The following is a description of a gene set: Human Gene Set: GOBP_GRANULOCYTE_DIFFERENTIATION species: Homo sapiens The process in which a myeloid precursor cell acquires the specialized features of a granulocyte. Granulocytes are a class of leukocytes characterized by the presence of granules in their cytoplasm. These cells are active in allergic immune reactions such as arthritic inflammation and rashes. This class includes basophils, eosinophils and neutrophils., and this is the list of marker genes: ZFPM1, CUL4A, CEBPE, CSF2, LYN, CEBPA, GATA2, LBR, SPI1, ZBTB46, NKAP, AP3B1, FAM3C, CEACAM1, LEF1, HCLS1 (hematopoietic cell-specific Lyn substrate 1), EVI2B, SP3, FOSL2, CBFA2T3, TRIB1, INPP5D, CITED2, GATA1, RARA, STAT5A, C1QC, FASN, PRDM16, HAX1, JAGN1, MIR486-1, L3MBTL3, ADIPOQ, IL5, SRP54, BAP1, CSF3, CLPB, TESC, RUNX1, TAL1, IL25